The following is a description of a gene set: Genes down-regulated in bone marrow-derived dendritic cells treated by CSF2 and 1,3-beta-D-oligoglucan: low dose versus high dose. from publication Min L, Isa SA, Fam WN, Sze SK, Beretta O, Mortellaro A, Ruedl C (PMID 22250091) A simultaneous engagement of different pathogen recognition receptors provides a tailor made adaptive immunity for an efficient defence against distinct pathogens. For example, cross talk of TLR and c-type lectin signalling effectively shapes distinct gene expression patterns by integrating the signals at the level of NF-κB. Here, we extend this principle to a strong synergism between the Dectin-1 agonist, curdlan, and an inflammatory growth factor, GM-CSF. Both together act in synergy in inducing a strong inflammatory signature which converts immature DCs to potent effector DCs. A variety of cytokines (IL-1β, IL-6, TNF-α, IL-2 and IL-12p70), costimulatory molecules (CD80, CD86, CD40 and CD70), chemokines (CxCl1, CxCl2, CxCl3, CCl12, CCl17) as well as receptors and molecules involved in fugal recognition and immunity such as Mincle, Dectin-1, Dectin-2 and Pentraxin 3 are strongly up-regulated in DC treated simultaneously with curdlan and GM-CSF. The synergistic effect of both stimuli resulted in strong IKBα phosphorylation, in its rapid degradation and in enhanced nuclear translocation of all NF-κB subunits. We further identified MAPK ERK, as one possible integration site of both signals, since its phosphorylation was clearly augmented when curdlan was co-applied with GM-CSF. Our data demonstrate that the immunomodulatory activity of curdlan requires an additional signal provided by GM-CSF to successfully initiate a robust β-glucan specific cytokine and chemokine response. The integration of both signals clearly prime and tailor a more effective innate and adaptive response against invading microbes and fungi. Human Gene Set: GSE32986_GMCSF_AND_CURDLAN_LOWDOSE_VS_GMCSF_AND_CURDLAN_HIGHDOSE_STIM_DC_DN species: Homo sapiens, and this is the list of marker genes: ALOX5, SYCE2, ABLIM1, STN1, HMGN1, NUDT18, TENT4B, DAG1, TMEM78, KDSR, HLF, NCF4, OSMR, IL1R2, ASB9, OR1S1, MYADM, MEDAG, MDFI, RNF32-DT, CYP3A4, TRIM47, ATOX1, ODAPH, PTPN13, LINC00299, TIFA, CD28, OR1L1, LRRC49, SH3BGRL2, PLXND1, PGAP2, DRC3, C3orf52, LTA4H, VLDLR (very low density lipoprotein receptor), CRADD, PDE5A, SATB1, TSHZ3, ITIH1, CDKN2D, GJA10, PGC, CEACAM21, DST, CPA6, CCDC197, PIGY, SCRN1, NRIP1, MIR302A, CAVIN3, CLIC4, C18orf21, STK24, SCUBE1, CCDC62, CYP27C1, TSPAN15, AIM2, MAML3, SOX14 (SRY-box transcription factor 14), KRTAP19-5, CASP12, HIVEP2, IRAK2, NARF, BTNL3, ANK1, RANBP3, MORN1, ANXA13, ZP3, CALML5, SRD5A3, SLC17A3, CREB3L3, SLC35G1, C10orf90, SLC12A2, MTERF2, PCDHB8, TPT1P9, PTGDS, IL23A, ETV1, TMEM9, ICA1, SMAP2, ADTRP, PXK, PPP2R2B, C1orf94, HSPA12A, CNGA3, ANO4, LRRC46, PRXL2C, CDH4, DIXDC1, KATNAL2, NBEAL2, GBP2, ETV7, MARCHF10, OLAH, PKIB, SPINK7, COLQ, SIRPB1, FAM107A, FAM230B, MSRB2, OR13C8, ANXA2, CHN1, FRMD4B, FAM138D, COA7, ZNRF1, NDUFAB1, LCE2C, CFAP68, MIR10B, PPP1R35, SIRPG, SH3GL2, MICOS13, OR5E1P, KIF5C, TDRKH, SCGB3A2 (secretoglobin family 3A member 2), AKR1C1, PPP1R36, ANXA2P1, SLC39A1, LGALS3, KTN1-AS1, RORB, PDE4DIP (phosphodiesterase 4D interacting protein), HLX, ITGAE, RGMB, FBXL21P, MAP7D3, TPTE2P3, PROCR, ASNS, TPD52L3, EDEM1, PADI2, C1orf127, CLMP, ZFHX4, ARR3, MAPK10, XIRP2, TTC22, SLC44A3, OR2F2, WDR49, KRT6A, UGT2B10, SCIMP, SOX5, RASSF6, MYCBP, LIMS1, CLDN14, RCL1, S100A4, WNT7A, ADRA1B, NSUN7, CTAGE1, LGALS1, BVES (NCBI Gene Id 11149), DMGDH (NCBI Gene Id 29958), UGT2B4, CYTIP, MATCAP1, TM6SF1, TEF, FERMT2, RS1, RHEBL1, RORC, JUN, METRNL, PLSCR4, RPS18P9, AP2B1, RNF148, TYRP1, SLC4A10, ALPK1, CDKN1A